Given this list of marker genes Syt7, Syt1, Adora2a, Abat, Syt4, Crhr2 (NCBI Gene Id 12922), Pcp4, P2ry12, Oprk1, Oxtr (NCBI Gene Id 18430), Slc18a2, Chga, Oxt, Nisch, Adora2b, Rab3a, Chrnb2, Sncg, Gnat1 (NCBI Gene Id 14685), Syt11, Gck, Ffar3, Myo5a, Drd2, Crhr1, Dtnbp1, Xlr4b, Sdhd, Rtn4, Adora3, Stx1a, Pink1, Slc18a1, P2ry1 (purinergic receptor P2Y, G-protein coupled 1), Chrna7, Cnr1 (cannabinoid receptor 1), Agt, Chrna6, Entpd1, Chrna4, Mecp2, Kpna4, Comt (NCBI Gene Id 319399), Xlr4a, Vip, Htr1b, Prkcb, Tgm2, Ptgs1, Snca, Cartpt (NCBI Gene Id 27220), Plcd1, Kcna2, Grm2, Grk2, Ghsr, Htr6, Ptger3, Gabbr1, Drd3, Kcnb1, Agtr2, Htr2a, Cxcl12, Hrh3, Cadps, Ly6e, Npy2r, Crh, here is a description of the gene set: The regulated release of catecholamines by a cell. The catecholamines are a group of physiologically important biogenic amines that possess a catechol (3,4-dihydroxyphenyl) nucleus and are derivatives of 3,4-dihydroxyphenylethylamine. Mouse Gene Set: GOBP_CATECHOLAMINE_SECRETION studied in species Mus musculus